The following is a description of a gene set: A cytoskeletal structure surrounding the axoneme and outer dense fibers of the sperm flagellum. Consists of two longitudinal columns connected by closely arrayed semicircular ribs that assemble from distal to proximal throughout spermiogenesis. The fibrous sheath probably influences the degree of flexibility, plane of flagellar motion, and the shape of the flagellar beat. Mouse Gene Set: GOCC_SPERM_FIBROUS_SHEATH studied in species Mus musculus, and this is the list of marker genes: Pgk2, Akap4, Ldha, Nme8, Gapdhs, Aldoart1, Tsga10, Akap3, Spa17, Aldoa (aldolase A, fructose-bisphosphate), Cabyr, Akap14, Gstm5, Fscb